Given this list of marker genes SLC30A4, DNAJC6, ELOVL7, ATG14, RECK, PKNOX1, CDK2AP1, SYNGAP1, SYT5, FAM120C, GSE1, ELK1, ZNF609, MCF2L2, HAS3, NR2C2, NRIP1, FMNL2, SP4, RNF6, KCNH8, BTBD7, ELMOD2, SDK1, CACUL1, DDAH1, MEF2D, LIMK2, FOXJ3, SLC31A1, INPP5J, MRTFA, PCDH17, HOMER2, PDE4D, ZNF827, DCBLD2, RORB, ERGIC1, TACC1, EYA1, ABHD13, ZNF800, AFF4, CPEB2, FBXO3, CD164, MTAP, SHC1, UBE2Z, AFAP1L2, CXXC5, UBE3A, TGFBR2, SOX6, PODXL, ZBTB18, SLK, CC2D1A, SLC39A10, LAPTM4A (lysosomal protein transmembrane 4 alpha), EPHA4, SH3D19, PHACTR2, AKAP13, ING3, RBM24, FBXL17, TSC22D2, LCOR, ZDHHC2, S100PBP, UBR1, KIF1B, PIP5K1C, BICRAL, GBA2, CBFA2T3, PTPRU (protein tyrosine phosphatase receptor type U), MAPT, ZC3H12B, ETV5, MKNK2 (MAPK interacting serine/threonine kinase 2), LARP4B (La ribonucleoprotein 4B), GTPBP1, CD2AP, ITSN1, EYA2, CPEB3, TBXT, SCN5A, CSRNP3, SNRK, FHIP1B (FHF complex subunit HOOK interacting protein 1B), KBTBD8, FURIN (NCBI Gene Id 5123), KCNJ2, CHD7, LPP, FAM91A1, NCOA1, PDZRN4, KLF9, ERG (ETS transcription factor ERG), DAZAP1, MFNG, ESR1, LPGAT1, PI4K2A, RTL9, TRAF7, CAMK2G, PHF19, OTX2, THRB, NTNG1, CCDC28A, EGR3, AGPAT3, ZCCHC24, PPP1R14B, UBASH3B, SKIDA1, PDGFRA, CBX2, NEK6, SEMA4G, ADD2, UBE2N (NCBI Gene Id 7334), CGNL1, PURG, ISL1, APPL2, TTBK1, INSIG1, CELF2, OCRL, ARID3B, DCP2, TMEM98, PPARGC1A, TRHDE, FZD4, here is a description of the gene set: Human Gene Set: GACAATC_MIR219 species: Homo sapiens Genes having at least one occurence of the motif GACAATC in their 3' untranslated region. The motif represents putative target (that is, seed match) of human mature miRNA hsa-miR-219 (v7.1 miRBase).